Given this list of marker genes RNF113A, ATP2B2, FAT3, GABBR2, FUT9, AP1S2, TFR2, XKR4, GRIA3, CALB2, SLC6A15, AMPH, FNDC9, FBLL1 (fibrillarin like 1), MAP3K9, FOXA1, LPCAT4, SLC32A1, MIR3917, RAPGEF5, TTLL7, SEZ6L, SAMD14, CBLN2, PRLR, GRIA1, COL8A1, GPRIN3, LYST (lysosomal trafficking regulator), EPB41L1, PSD, MAGI2, PLXNA3, CNTN1, KCTD8, TMEM196, GPC2, CAMK2B, GPR68, STMN4, AKR1C2 (aldo-keto reductase family 1 member C2), ZC2HC1A, AKAP1, CTNNA2, ACSL4, AKR1C1, NEGR1, SEMA6D, ACTL6B, LAMC2, TH, UBE2QL1, BEX5, POU2F2, MIAT, C2CD4C, TENM1, RIMS1, ELAVL4 (NCBI Gene Id 1996), PIANP, PTGES3L, SPINT2, RAB9B, GAP43, ARHGAP23, TMEM132B, ANK2, PLCXD3, L1CAM, ADCY2, SRCIN1, EEF1A2, ROBO1, ACVR1B, MYO5A, UGCG, BIN1, NSG2, NCDN, FSD1, ANK3, GRIP1 (glutamate receptor interacting protein 1), OPN5, GLCE, IGF1, NNAT, SYT7, CLCN4, TSPAN13, TMCC3, GRIN3A, ARL8A, SCN3B, PAPPA, PNMA8B, PLPPR4, XIST, HPCAL4, EEPD1, PDZD7, SERINC1, TMEFF2, SNAP91, ZNF33B, MAST2, LMX1A, CTTNBP2, EHBP1, NAP1L3, GALNT17 (polypeptide N-acetylgalactosaminyltransferase 17), RFPL1S, PRKCA, BASP1, KCNN3, RIMS2, GNAZ, LRRC3B, DNASE1L1, STMN1, KLHL32, GNG3, NLK, PLEKHA1, RAB11FIP4, PPP2R3A, SOBP, HOOK1, CCDC136, NFIX, ACOT7, PBX3, IRGQ, SLC4A3, RBFOX2, SCG3, ENC1, CACNA1E, CDC42EP3, ANKRD36B, HBG2, PRKX (protein kinase cAMP-dependent X-linked catalytic subunit), GPRASP1 (G protein-coupled receptor associated sorting protein 1), GABRA2, CNGB1, PPFIA2, SLC4A8, MUC19, CD27-AS1, C1QL1, PLXNA4, NECTIN1, SLC17A6, SYT4, SMIM18, GLRA2, GNG2, KCNIP4, TRIM67, SRGAP1, FAXC (NCBI Gene Id 84553), PRKCZ, ERBB4, JPH4, LRRC55, RNF14 (NCBI Gene Id 9604), BEX2, ROBO2, TBC1D3, JUP, TUBB3, CLUL1, DACT1, EBF2, GFRA1, ENO2, SVOP, LRRC7, DRAIC (NCBI Gene Id 145837), DCLK1, SSTR2, GRIA4, SMPD3 (NCBI Gene Id 79756), CSMD1, HBA2, SLC1A4, PLPPR2, ARHGEF3, CLSTN2, TERF2IP, INSM1, ANKRD55, GPM6A, IRF2BPL, MTUS2, UNC79, ATCAY (NCBI Gene Id 85300), TMEM35A, EBF3, REEP1, SLC24A3 (NCBI Gene Id 96617), APP, SHF, PIP4P2, CCSER1, CHRNA7, SEMA3D (NCBI Gene Id 223117), SLC18A1, TRIM38, UBASH3B, SNAP25, KLF7, CTXN2, HS3ST4, FAM217B, RIPOR2, STOX2, CA1, APLP1, NTSR1, CASZ1, RTL9, ZNF568, CACNG2, PLXNC1, FAM13C, SCN9A, TMEM169, PRKACB, SYT13, GABRG2, APOL6, DOK4, NLGN4X, NREP, CPNE4, TAC1 (NCBI Gene Id 6864), SH3BP5, PTK2B, ATP8A1, DCX, SULT4A1, LSAMP, CPEB4, EID2B, XPR1, MACO1, CDH4, IGSF9, DNM3, PGM2L1, ZFP69B, EN1 (engrailed homeobox 1), ARMH4, NEDD4L, PBX1, MTURN, KIFC2, RELN, NCAM1, RTN1, SCARNA22, KCNMA1, SH3PXD2A, GNAL, TM2D3, EPHA5, TSPAN7, NR4A2, LDB2, YWHAG, MAP1B, AKAP12, TAFA1, TMEM178B, TAGLN3, NALF1, RETREG1, KLHL1, MAP2 (microtubule associated protein 2), TCEAL5, KIF21B, TMEM88, COLQ, OPTN, C22orf42, KLHL29, NRXN3, INHBA-AS1, GARNL3, ZFHX3, TERF2 (telomeric repeat binding factor 2), EDIL3, SCN3A, UCHL1, HPGD, VWA5A, CELF5, ZNF57, PDE4DIP, MLLT11, PCDHGC4 (protocadherin gamma subfamily C, 4), FOXP2, PHACTR3, SHROOM2, KCNQ3, TMEM74B, NMNAT2, RNF112, NEB, KLHL35, GNAO1, SRRM4, CHL1, DNER, TMEM185B, FNBP1, LHFPL4, MAB21L1, GPR85, KIF5C, STAR, DPP6, STMN2, AJAP1, MED12L, SERTAD4, ANKRD13B, NAV3, CAMK2N1, MIR124-2HG, DLG4, DAAM1, FGF9, CELF4, REEP2, KLHL14, EN2, CLVS2, GABRB3, THSD7B, HBA1, SHTN1, ICA1L, TTC9B, SCD5, MYRIP, PTPRO, ADCY8, RASSF5, RALGDS (ral guanine nucleotide dissociation stimulator), FNDC5, GSE1 (NCBI Gene Id 23199), SNORD116-29, ELOVL4, EBF1, ASNS (asparagine synthetase (glutamine-hydrolyzing)), CHD5, OR4N2, PRKCB, GRIP2, CYRIA, PTPN5, SLC16A14, FRMD3, FSTL4, SCG5, MMP24, CD2, PDZRN4, RALYL, DDC, BCL11A, SEZ6L2, GDAP1L1, CHGA, CHST1, ELAVL2, TMEM121B, SOX11 (SRY-box transcription factor 11), TLE2, PLEKHM3, SDC1, CELSR3, ACSL5, ADARB2, ANK1, PID1, DPYSL3, PRRT2, PAK5, LMTK3, ELOVL3, SLITRK1, TPPP, CADM1, CRHBP, DLG2 (discs large MAGUK scaffold protein 2), NSG1, TMEM163, RGS6, CADPS (calcium dependent secretion activator), ADA2, GRM8, MYT1L, HBG1, MSANTD3-TMEFF1, TMEM59L (transmembrane protein 59 like), ATP1A3, C1orf35, FJX1, SLITRK4, SLC8A2, PCDH1, BICRAL, CLVS1, HIVEP3, KCNAB1, SH3GL3, ERC2, TOX2, CSRNP3, NTNG1, NRXN2, CD24, SHANK2-AS1, ANKRD12, RAP1GAP2, TUBA1A, NFE2L3, PLEKHA6, DOCK4, ROCK1, SV2A, FOXA2, PWAR1, CDH13, TRIM46, TUBB2B, NYAP1, SBK1, BIVM-ERCC5, SCN2A, PARP8, NRXN1, DOK6, CGN, SLC39A8, YPEL2, SNORA12, FBXL16, KIF3A, GOLGA7B, SLC12A5, SYNJ1, NPY1R, MAP3K11, PPP1R21, ELAVL3, TMOD2, VAV3, SV2B (NCBI Gene Id 9899), MEG3, SHISAL1, CRMP1, ULK3, DIRAS3, GRIK2, ZFHX2, ARG2, NTM, GRIK3, CXADR, PKIA, PITX3, ZBTB38, OLFM3, DLK1, COBL, CDK5R1, GABRB1, INA, FGF13, SEMA3E, ZNF697, SMURF1, ZGLP1, RUNDC3B, LY6H, ZCCHC12, DSCAM, DGKE, UNC13A, ZNF385D, CHRNA4, DMTN, PAK3, PRDM8, PAK6, CELF3, MAST1, HERC2P4, PSD2 (NCBI Gene Id 84249), CEP126, MUC16, OPRK1, PRKAR1B, here is a description of the gene set: from publication La Manno G, Gyllborg D, Codeluppi S, Nishimura K, Salto C, Zeisel A, Borm LE, Stott SRW, Toledo EM, Villaescusa JC, Lönnerberg P, Ryge J, Barker RA, Arenas E, Linnarsson S (PMID 27716510) Cell types are named using anatomical and functional mnemonics prefixed by 'm' or'h' to indicate mouse and human respectively: OMTN, oculomotor and trochlear nucleus; Sert, serotonergic; NbM, medial neuroblast; NbDA, neuroblast dopaminergic; DA0-2, dopaminergic neurons; RN, red nucleus; Gaba1-2, GABAergic neurons; mNbL1-2, lateral neuroblasts; NbML1-5, mediolateral neuroblasts; NProg, neuronal progenitor; Prog, progenitor medial floorplate (FPM), lateral floorplate (FPL), midline (M), basal plate (BP); Rgl1-3, radial glia-like cells; Mgl, microglia; Endo, endothelial cells; Peric, pericytes; Epend, ependymal; OPC, oligodendrocyte precursor cells. species: Homo sapiens Human Gene Set: MANNO_MIDBRAIN_NEUROTYPES_HDA